Given this list of marker genes Ppp2r2c, Nkd1, Ppp2r2b, Ppp2r3d, Ptpa, Ppp2r5d, Ppp2ca, Ier5, Ppp2r5b, Ppp2r1a, Ppp2r2d (NCBI Gene Id 67813), Ppp2r1b, Ppp2r5a, Ppp2r3a, Ppp2r5c, Ppp2cb, Ppp2r5e, Ppp2r2a, here is a description of the gene set: Mouse Gene Set: GOCC_PROTEIN_PHOSPHATASE_TYPE_2A_COMPLEX studied in species Mus musculus A protein complex that has protein serine/threonine phosphatase activity that is polycation-stimulated (PCS), being directly stimulated by protamine, polylysine, or histone H1; it constitutes a subclass of several enzymes activated by different histones and polylysine, and consists of catalytic, scaffolding, and regulatory subunits. The catalytic and scaffolding subunits form the core enzyme, and the holoenzyme also includes the regulatory subunit.